The following is a description of a gene set: Genes predicted to be targets of miRBase v22 microRNA hsa-miR-378g in miRDB v6.0 with MirTarget v4 prediction scores > 80 (high confidence targets). studied in species Homo sapiens Human Gene Set: MIR378G from publication Chen Y, Wang X (PMID 31504780), and this is the list of marker genes: ERI3, TMEM38B, SRXN1, MGAT5 (alpha-1,6-mannosylglycoprotein 6-beta-N-acetylglucosaminyltransferase), PLEKHM1, MITF, PRKAB2, ILRUN, MTMR3, TRNP1, PLEKHM3, CLCNKB, SYT6, TANC1, ARMC5, CYB5RL, HMGN2, SERINC4, SKIL, LEF1, GIPC3, PHF21A, SEC16A, IQSEC3, C1orf226, MAVS (mitochondrial antiviral signaling protein), FNDC3A, IFI30, CDH1, IFT122, PTPRH, MICAL2, FBXO33, SSBP2, KDM2B, BCL2L2, AHI1, SLC39A4, NF2, SRGAP1, ERLIN2, CACNA1I, CRABP2, ISCU, ERLIN1, SPECC1L, ARRDC3, PAF1, NINJ1, KCNA5 (potassium voltage-gated channel subfamily A member 5), SLC23A2, WDR33, FBLN5, ERBIN, KPNA6, ALDH3B2, TPD52, ALPK3, SPCS1, SPEF1, TRABD2B, CNTN1, FCRL3, KCTD20, NOS1AP, SH3PXD2B, ENG, NT5E, SEC31B, ADAM12, PPM1A, TRMT5, ANKRD53, ACP6, ETV1, KDM2A, RIMS4, KCNIP3, UBE2N, CBR1, NFASC